The following is a description of a gene set: Human Gene Set: GOMF_INTRONIC_TRANSCRIPTION_REGULATORY_REGION_SEQUENCE_SPECIFIC_DNA_BINDING Binding to an intronic DNA sequence that regulates the transcription of the transcript it is contained within. studied in species Homo sapiens, and this is the list of marker genes: SMYD3, GRHL2, HSF1, ZNF350, BCL6, ZC3H8, VAX1, HSF2, VAX2, NKX2-1, NCOA2